Given this list of marker genes Rpl37a, Rpl37rt, Rps27l, Rplp2, Rpl9, Rps7, Rpl36a, Rps26, Eif5b, Eif2s3x, Rpl12, Rps13, Rps4x, Eif3f, Rps6, Eif3b, Rps15, Pabpc1, Rpl24, Eif3e, Ubb, Rpl11, Rps25 (NCBI Gene Id 75617), Rpl3, Rpl15, Rpl7, Rpl4, Rps3a1, Rps8, Eif3g, Eif3j2, Rpl27, Eif4a1, Rpl29, Rps9, Rpl19, Rps18, Eif2b4, Rpl39l, Rpl39, Eif3d, Eif4ebp1, Rps10, Fau, Rps12, Rps24, Rpl3l, Rpl37, Rpl18, Rpl6, Rpl38, Rpl27a, Rpl13, Rpl18a, Eif1ax, Eif4a2, Rpl36al, Rps2, Rps23, Eif3k, Eif3i, Rps20, Rps11, Rps5, Rpl26, Rps19, Rps28 (ribosomal protein S28), Rpl14, Rps17, Rpl23a, here is a description of the gene set: Reactome Pathway: Eukaryotic Translation Initiation part of: Translation This event has been computationally inferred from an event that has been demonstrated in another species.<p>The inference is based on the homology mapping from PANTHER. Briefly, reactions for which all involved PhysicalEntities (in input, output and catalyst) have a mapped orthologue/paralogue (for complexes at least 75% of components must have a mapping) are inferred to the other species. electronically inferred by orthology from the curated human pathway species: Mus musculus